Given this list of marker genes Racgap1, Sgo1, Arhgap33os, Snhg15, Cenpq, Nudc, Kif18a, Zfp207, Mapre1, Eml4, Ttl, Spice1, Cul3, Chmp2b, Abraxas2, Dctn2, Ccnb1-ps, Ccdc66, Kif22, Kat5, Mlh1, Chmp1b, Vps4a, Ndc80, Apc, Spc25, Birc5, Seh1l, Spdl1, Rab11a, Cenpc1, Pibf1, Spc24 (SPC24, NDC80 kinetochore complex component, homolog (S. cerevisiae)), Ska3 (spindle and kinetochore associated complex subunit 3), Kif2b, Spag5, Chmp1b2, Nek2, Map1s, Aurkb, Vps4b, Zwint, Ska2, Rcc2, Fam83d, Knl1, Knstrn, Chmp6, Psrc1, Tex14, Becn1, Kifc5b (NCBI Gene Id 94117), Sirt1, Pinx1, Brca2, Gem, Nsl1, Dsn1, Numa1, Cdca8, Nuf2, Kat2b, Kif14, Incenp (inner centromere protein), Cenpe, Eml3, Cdc23, Ska1, Cdc42, Kpnb1, Mad1l1, Zw10, Hnrnpu, Ttk, Chmp4b, Chmp4c, Rrs1, Abraxas1, Chmp3, Trappc12, Chmp1a, Chmp7, Ankrd53, Cenpf, Cdca5, Cdt1, Nup62, Kif2c, Meioc, Dync1h1, Rb1, Champ1, Sirt2 (sirtuin 2), Kifc1, Ccnb1, Septin1, Pmf1, Ect2, Mis12, Cdk1, Chmp2a, Chmp5, Bub3, here is a description of the gene set: studied in species Mus musculus A chromosome localization process whereby chromosomes are positioned in a specific order and orientation at the metaphase plate (spindle equator), during chromosome segregation. This alignment ensures that each daughter cell will receive the correct number of chromosomes during cell division. Mouse Gene Set: GOBP_METAPHASE_CHROMOSOME_ALIGNMENT